Given this list of marker genes SMARCD3, SCRIB, FGFR3, NCOA6, GSE1, LILRB2, THAP10, PTGR3, ERBB2, LHPP, MTFR1L, BRI3BP, VIPR1, GADD45A, C16orf87, GAA, ARRDC3, KLB, CES5A, VILL, MIF4GD, ZNF319, ADCK2, G0S2, GMPS, TFPT, SCGB3A2, DRD3, NFIC, ADCYAP1, HDDC3, XPNPEP3, PRR12, PDE4DIP, RNF207, LZIC, DPPA5P4, ATG7, UNC119B, RGS1, TTLL12, RPUSD2, TRIB3, RNF152, TRADD, DYNLRB1 (NCBI Gene Id 83658), CFLAR-AS1, STX10, SETX, PEX19, PTPRN, SPMAP1, SLC35G1, NMBR (NCBI Gene Id 4829), RAB15, ADGRL1, MECR, VNN1, FREM3, PGP, TSIX, SSBP4, IL20, SLC9A3-OT1 (NCBI Gene Id 25845), SOCS3, ZBTB45, CLEC4E, KTN1, COL6A3, TMEM132B, C4BPA, FAM78A, PGLS, REPIN1, PPP3CC, DUSP1, KLF4, FDCSP, MGRN1, STK16 (NCBI Gene Id 8576), ARRB2, SOX7, ZMYM3 (zinc finger MYM-type containing 3), GRINA, PARP3, SH3BP2, PET117, COL12A1, RAP1GAP2, TMEM141, LMNTD2, CLPP, NAA40, NUDT22, CECR9, MAPKAPK3, LDB2, JUNB, CDCA7, JUN, TSC22D1, CLIP2, TMEM145, IRS1, TPRN, ANKS6 (NCBI Gene Id 445575), SLC25A22, MCOLN1, CMA1, TMED3, XXYLT1, SAMD10, THAP4, FAM204A, SNTB2, ARIH2OS, DDIT4 (NCBI Gene Id 54541), LINC00173, AKTIP, VAMP5, CDR2-DT, MYL6B, ITGB3BP, TRAF5, MCRIP2 (MAPK regulated corepressor interacting protein 2), TOR2A, GUCY2C, C20orf181, GBP5, AGPAT1, IFI30, CAMSAP1, ENSG00000288011, ZBED10P, TMUB1, TRIM2, TRAPPC1, MAGEE1, HORMAD1, TUBGCP4, NAPB, FGR, CMTM7, TAMM41, CADPS2, TRABD2A, ZNF792, SFXN5, KLHDC9, ABCC8, PACS2, CHRNA3 (cholinergic receptor nicotinic alpha 3 subunit), CNPY4, ALKBH7, THNSL2, PCIF1, ST7L, WFDC11, FGF5, CHRNB4, RASSF7, ACAP1, C1orf159, SOCS6, RPAP1, ASB16-AS1, CCDC124, ATG16L2, NHERF1, CCDC71L, HTR1E, TBC1D10A, BIN1, PTPMT1 (protein tyrosine phosphatase mitochondrial 1), EHD1, PUSL1, RGS2, KXD1, PPIH, TP53AIP1, MINDY2, SEMA5B, ROGDI, NDST3, NEURL1, IMPG1, WDR27, YIPF2, CEP170B, DNASE1L1, VPS26B, U2AF1L4, SNUPN, SUPT20H, here is a description of the gene set: Human Gene Set: GSE17974_CTRL_VS_ACT_IL4_AND_ANTI_IL12_1H_CD4_TCELL_UP The aim of this dataset was to study in detail the transcription kinetics initiated by cytokine IL-4 in early differentiation of Th2 cells. Genes up-regulated in comparison of untreated CD4 T cells at 0 h versus the cells treated with IL4 and anti-IL12 at 1 h. from publication Elo LL, Järvenpää H, Tuomela S, Raghav S, Ahlfors H, Laurila K, Gupta B, Lund RJ, Tahvanainen J, Hawkins RD, Oresic M, Lähdesmäki H, Rasool O, Rao KV, Aittokallio T, Lahesmaa R (PMID 20620947) species: Homo sapiens